Given this list of marker genes GIGYF1, NANOS1, ZFHX4, IRF1, PAFAH1B2, TNRC6B, WAC, AQP4-AS1, ADGRL2, CTDSPL2, FOXJ3, XRN1, CDK10, PPA2, ARK2N (arkadia (RNF111) N-terminal like PKA signaling regulator 2N), EEIG1, ARID4A, SCML2, URI1, PAFAH1B1, FAT2, SKIDA1, ARL4C, RRM2, PLAGL2, GATAD2B, CLOCK, DAZAP2, RBL2, BAZ1B, RETREG2, PPP2R2A, TAGAP, DDX3X (DEAD-box helicase 3 X-linked), MAP3K7, KAT6A, MYLK (NCBI Gene Id 50483), PTEN, PCYT1B, BCL11B, EPHA7, NBEA, ZBTB7A, ST8SIA2, SEMA4G, BNIP2, NR4A2, KDM1B, PTPRG, CORO7, MKRN1, FURIN (furin, paired basic amino acid cleaving enzyme), PTPRD, SPATA2, BCOR, TBL1X, MARK2, FAM53C, TMEM131L, FBXO21, DDX3Y, CCNT2, VPS26A, FGD1 (NCBI Gene Id 2245), FAM13B, ZFP91, S1PR1, BTBD7, CADM1, SRPK1, SIKE1, DKK1, QKI, YPEL4, ARID4B, C1GALT1, SOX11, ARHGEF5, RPS6KA3, SON, OGA, DLL1, ZNF385A, EIF4H, GAN, PHF1, NR2F2, KIF3B, NEDD4L, BICD2 (NCBI Gene Id 23299), ARHGEF12, UBR5, CXCR4, MAT2B, EHD3, EIF5A2, NPAS2, AGO1, MMD, DCUN1D3, MOB1B, EFNB3, SYNE1, MMP19, MARK4, ZIC4, RAB35, SERTAD2, DPYSL5, SP1, TM9SF3, OPCML, UBE3C, ZNF148, PTPN3, LBP, CCNG2, RAB5B, OSR1, ITPRID2, PTGFRN, ZBTB4, MTMR4, ESRP1, here is a description of the gene set: Genes having at least one occurence of the motif GGCACTT in their 3' untranslated region. The motif represents putative target (that is, seed match) of human mature miRNA hsa-miR-519e (v7.1 miRBase). species: Homo sapiens Human Gene Set: GGCACTT_MIR519E